The following is a description of a gene set: Genes containing one or more binding sites for (ZNF213) in their promoter regions (TSS -1000,+100 bp) as identified by GTRD version 20.06 ChIP-seq harmonization. species: Homo sapiens Human Gene Set: ZNF213_TARGET_GENES from publication Yevshin I, Sharipov R, Kolmykov S, Kondrakhin Y, Kolpakov F (PMID 30445619), and this is the list of marker genes: CCDC169, H1-0, SNHG6, EFTUD2, ZCWPW1, COPS3, CWC25, PSMA2, MFSD11, DCAF5, FAM117B, FBXO36, ZFAND5, MYNN, TSC1, TAP2, DLL1, PSD, RND1, LIMD1-AS1, NDUFAF1, KIAA0825, NBPF11 (NCBI Gene Id 728912), ESYT1, SPAG7, RPL12, KBTBD4 (NCBI Gene Id 55709), ITFG2, GNB2, AURKAIP1, SSBP2, FES, FADS2, RFC1, ASS1P5, PRNP, BRPF1, GFOD2, SUZ12P1, C3orf52, ZNF212, DMAP1, USP47, RBM34, CCDC169-SOHLH2, MED23, WNT10B, LINC02585, MIR615, CPEB3, DRG2, TLE6, FRA10AC1, ZBTB45, TOB2, FGD5-AS1, RFTN1, MEF2C-AS2, ADO, TGS1, ANGEL1, NR2C2, TNFRSF12A, EGLN2, SEMA6A, HEBP2, GGA1, ANKRD37 (ankyrin repeat domain 37), SGSM1, PSMC3, SH3PXD2B, USP30, SPATS2L, CPEB4, CUL4A, MFSD14CP, RCOR1, VPS51, TRMT1, TMOD1, ABTB1, RNF40, MBTD1, SRSF2, BRWD1, ITFG2-AS1, ZNF607, WDR11, GSTCD, WDFY3, FANCD2, RPS29, YTHDF2, RCAN1, ENSG00000235480, ZBTB24, CELSR3, SCN4B, MIR3197, EIF2D, SNRNP70, ADAP2, SNAP29, SLC24A1, LRRC24, ENPP3, TMEM68, H4C11, TCTA, PCID2, OTULIN, GSE1, ELP3, GGCTP1, PSMG2, BRF2, MIR3162, RNVU1-14, KDM4B, SGMS1, ASH2L, GAS2L3, CFAP221, AKIRIN2, AP3D1, SBNO1, FRMD4B, TAB2, TBPL1, PPIL4, NKIRAS1, DTL, RGS5, RNF24, SMARCE1 (SWI/SNF related, matrix associated, actin dependent regulator of chromatin, subfamily e, member 1), SPTY2D1, SAMD11, MRPL39 (NCBI Gene Id 64977), AGBL5, IQGAP2, RBBP5, GPN2, ENSG00000232995, ARHGEF2-AS2, SYMPK, KLF2-DT, NOP16, HOXB9, SLC11A2, ZYX, KDM5A, RABGAP1, ZMYND15, ADPGK, KBTBD11, MRM3, CROCCP3, CDIP1, ANGPTL6, SPMIP8, RAB33B, RPS15, TATDN3, KIRREL1, CDC34, INTS14, MED19, TPT1-AS1, CSNK1D, CCNI, PRPF31, HEXIM1, IRF9, MIR194-1, ZMYM4, PRKAR2A-AS1, GFI1B, TMEM44-AS1, MAP3K7, LINC01012, SNHG7, AGBL5-AS1, TRIM26, GLYR1, B4GAT1-DT (B4GAT1 divergent transcript), ZSCAN16-AS1, SNHG30, CNKSR3 (CNKSR family member 3), FAM133B, SLFN12, WLS, HNRNPMP2, EXOSC2, RTN3, EXTL3, ACAP3, CACYBP, DCP1A, LRP6, ZBTB40, AURKB, RTN2, REXO5, TM9SF1, GDI2, QKI, ZDHHC5, PTPA, CDCA2, NRN1, HOXB3, NUF2, MTF2, KCTD13-DT, PMM1, ENSG00000188897, KRT8, NFE2L2, BOLA3-DT, CD160, TLL1, DPH7, NOTCH2NLA, SYCE1L, SDC4, PRKAA1, DDX55, MRRF, ZNF518B, PUSL1, C6orf52, SFSWAP, FAM120AOS, CDKN2AIPNL, TOR1A, CHST11, KDM1A, FBXL15, PI4KA, PDK4-AS1, GRHL3-AS1, CHD3, NATD1, ANKRD54, SMAD7, ENAH, HOXB6, ENSG00000244137, MIR3190, ZEB2, CLTC, NICN1, ARHGAP24, BACE2, LINC02609, TRIM59, METTL13, GRN, ACER3, TP73, TRIP12, TMEM86A, SEC22A, KCTD9 (potassium channel tetramerization domain containing 9), RNU6-166P, PDK4, KMT2D, GMFB, TMEM87A, PIH1D2, GOLM2, PAMR1, PTPN13, UBN1, GPS2, SH2B3, B4GAT1, EMX2, EGR3, LINC01881, TESC, TESC-AS1, MIR3613, PTPRO, CCDC103, MED30, GNA13, ENSG00000247416, AGPAT3, MRPL32, ARL1, MNT, NLE1, PRICKLE1, HARBI1, ANKRD10, ARHGEF2, ADA, ATG13, CRYM, TGFB1, FCHO2, NCAM1, ISLR2, LUC7L, TSEN15, EARS2, GALNTL5, DISP3, LYPLA2P1, ERI2, HEXA-AS1, CCDC127, PHKB, NFKB1, ITGAL-AS1, ARID1A, EIF3F, STX4, MEPCE, SRPK2, PDE4A, ZNF92, LIPA, YOD1, SH2D3C, NDUFS3, DDX5, NOL6, GANC, CEP95 (NCBI Gene Id 90799), TM7SF3, MRPS15, VCAN, NDC1, EMX2OS, PAFAH2, WARS2, FBXL17, SNX25P1, GUSBP1, PYGO2, SMG7-AS1, TRMT2B, KLHDC8B, KLHDC9, TTLL13, WDFY3-AS2, SLC25A51, RPL32P27, ATAD3A, CDK4, MIR3928, INTS12, SMG7, ZNF3, CCDC77, TMX2, FAM53C, TRIM15, FABP5P3, CFAP119, RPS27 (ribosomal protein S27), MTO1, CCDC65 (NCBI Gene Id 85478), LINC00466, SEPTIN9 (NCBI Gene Id 8162), NUCKS1, RN7SL1, HSPA4L, SORBS1, H4C8, TFPT, TIGAR, NCKAP1L, MED21, RPL36, N4BP2, ATF7IP, KCTD13, KXD1 (KxDL motif containing 1), NKAPD1, SACM1L, GADD45B, RPA3 (replication protein A3), MAP3K5, LINC01132, MTARC1, PITPNA, FAM76A, MARCHF5, PLEKHG2, SRRM2-AS1, CDC25C, CLCC1, RPL39P40, COQ3, PDIA4, CHPT1, DNAJB12, RFX1, SOCS2, MIR548AW, RPL30P11, FAM131B-AS2, AASS, DDB2, BCL11B, ENOX1, FASTK, PDZD9, UBE3D, NBPF14, BOLA3, SS18, KITLG, SYVN1, EBF3, RP2, QSER1, FAM187A, HAPLN2, RBM18, ITGB3BP, CXCL16, DLEU2, RRN3P1, GIT2, GRHL3, SIN3B, PAK1IP1, SBF2, LASP1, GINS4, CEP76, RPL15, FRMD7, ZNF747-DT, DNAJC3-DT, ARHGEF3, TRAF6, KNSTRN, FOXA3, ZC3H10, FAM120B, SDAD1P3, UMAD1, LRSAM1, NXN, ARL15, SSBP1, XXYLT1, REXO4, SRRM2, APP, EXOG, DUS1L, CNOT1, HPS1, WARS2-AS1, R3HCC1, RPS6KA2, SMARCD2, FAM120A, MED15, INO80, CCDC144BP, IZUMO4, SAV1, EFCAB7, PRDX2, UCK2, CYP2S1, EVA1C, INTS7, HMGA1, ETV2, RPL28, BHLHE22-AS1, ARMC8, CSNK1E, TIMELESS, SENP2, RNF185, PRSS27, ADPRS, RIGI, CCNL1 (NCBI Gene Id 57018), CENPBD2P, TPT1, TEFM, NBN, CAPS2, FLNA, WDR11-DT, OTULIN-DT, CBLL1, DSC3, PPM1N, PDE4D, LINC01485, MORF4L1, ZC3H4, ZNF747, GARNL3, ZNF629, GABBR1, DCLK1, LRP2BP (LRP2 binding protein), MARK1, WEE1, NAA20, DNAJC3, DCP2, SREK1, ZEB2-AS1, TRIM13, FAM149A, PLA2G15, LRRC8B, LAMP1, GARS1-DT, ILF2, GBA1, ANKRD17-DT, ZNF839, TSFM, CILK1, USP35, GLOD4, MIDEAS (mitotic deacetylase associated SANT domain protein), PDE12, WEE2-AS1, RAB39A, MOB3A, WDR24, SAE1, PDP1, WNT8A, CCDC122, FCHO2-DT, FCGRT, LINC03100, MIR759, DPP9, HSD17B1-AS1, NPAS3, UBFD1, BAZ1B, GARS1, COMTD1, MTFMT, SLC35F2, UBQLN2, CSNK2A2 (casein kinase 2 alpha 2), KCTD21, NSL1, CBX4, TOP3B, GLG1, NEURL1B, ZC3H6, C1orf87, LUZP1, LINC01235, PAPOLA, KAT8, MAML3, RHOA, MTMR8, CALM2, AGMAT, ITFG1, TTC1, HEXA, RANBP9, GPAT3, RAG1, RPL27, ANKRD17, STN1, SLC39A3, TMEM248, ANKRD13A (NCBI Gene Id 88455), CIDECP1, LURAP1L-AS1, RBSN, TMEM141, JPX, UFC1, PYGO2-AS1, CALM1, PRKAR1A, NDUFAF5, BPNT1, ESF1, SPEF2